The following is a description of a gene set: Mouse Gene Set: GOMF_FRUCTOSE_2_6_BISPHOSPHATE_2_PHOSPHATASE_ACTIVITY Catalysis of the reaction: D-fructose 2,6-bisphosphate + H2O = D-fructose-6-phosphate + phosphate. studied in species Mus musculus, and this is the list of marker genes: Pfkfb3, Pfkfb1, Pfkfb4, Tigar, Pfkfb2